Given this list of marker genes ST8SIA5, FUT2, B4GALNT1, A4GALT, UGCG, B4GALT5, B3GALNT1, ST6GALNAC6, ST3GAL3, UGT8, ST6GALNAC5, ST3GAL5, ST3GAL2, B4GALT6, FUT1, B3GNT5, B3GALT4, GAL3ST1, CERK, here is a description of the gene set: Reactome Pathway: Glycosphingolipid biosynthesis part of: Glycosphingolipid metabolism The steps involved in the synthesis of glycosphingolipids (sphingolipids with one or more sugars attached) are annotated here (the topic is reviewed by Sandhoff & Sandhoff, 2018; Sandhoff et al, 2018). species: Homo sapiens